The following is a description of a gene set: Mouse Gene Set: MIR_6414 species: Mus musculus Genes predicted to be targets of miRBase v22 microRNA mmu_miR_6414 in miRDB v6.0 with MirTarget v4 prediction scores > 80 (high confidence targets). from publication Chen Y, Wang X (PMID 31504780), and this is the list of marker genes: Xpot, Myct1, Zzz3, Tmem68, Crisp4, Npas3, Zfhx4, Ppp4r3b, Cfap298, Tm9sf2, Lrp5, B230219D22Rik, Ncoa6, Rwdd1, Immp1l, Selenot, Fam169a, Pptc7, Ncor1, Lrp2bp, Hsf2bp, Ctsc, Golt1b, Etnk2, Cbfb, Pals1, Rp9, Smc6, Mdga2, Rnf38, Cacnb4, Ccdc71l, Rrp36, Mrps2, Fam114a1, Ywhae, Ap5m1, Slc25a33, Tfpi2, Cldnd1, Rab9b, Pcsk5, Tmem267, Eva1a, Zc3h12c, Ildr1, Nxpe4, Ccl22, Cdc73, Hars2, Pds5b, Setd6, Camkk2, Rprd1a, F2rl1, Inpp4b, Radx, Actmap, Bloc1s6, Fbln2 (fibulin 2), Pi15, Slc40a1, Bccip, Akna, Bhlhe22, Zyg11b, Insyn2b, Clca2, Krt33a, Wdr26, Etf1, Rubcnl, Slc45a4, Wdr11, Egfem1, Ubfd1, Dido1, Cd2ap, Daam1, Eif4enif1 (eukaryotic translation initiation factor 4E nuclear import factor 1), Zfp846, Pi4k2b